Given this list of marker genes PRKAR1B, PRKACA, PRKACG, PRKAR1A, PRKAR2A, PRKAR2B, PRKACB, here is a description of the gene set: Human Gene Set: KEGG_MEDICUS_REFERENCE_PKA_HOLOENZYME studied in species Homo sapiens PKA holoenzyme. Pathway ID: N01542. Pathway type: Reference. Pathway class: nt06310 CRH-ACTH-cortisol signaling. Pathway Definition from KEGG: PRKAR -| PKA